The following is a description of a gene set: species: Mus musculus Catalysis of an oxidation-reduction (redox) reaction in which the hydrogen donor and acceptor are the same molecule, one or more carbon-carbon double bonds in the molecule are rearranged, and no oxidized product appears. Mouse Gene Set: GOMF_INTRAMOLECULAR_OXIDOREDUCTASE_ACTIVITY_TRANSPOSING_C_C_BONDS, and this is the list of marker genes: Hsd3b9, Idi1, Gsta1, Hsd3b1, Hsd3b3 (hydroxy-delta-5-steroid dehydrogenase, 3 beta- and steroid delta-isomerase 3), Hsd3b2, Gsta2, Mif, Eci3, Hsd3b8, Hsd3b4 (hydroxy-delta-5-steroid dehydrogenase, 3 beta- and steroid delta-isomerase 4), Idi1-ps1, Hsd3b5, Idi2, Hsd3b6, Ebp, Ech1, Eci1, Idi2l, Ehhadh, Ebpl, Echs1, Gsta5, Eci2, Dct, Gsta13